Given this list of marker genes TNFSF15, DLL1, AK4, ADAM19, TAB3 (TGF-beta activated kinase 1 (MAP3K7) binding protein 3), EHD1, TGFA, LINC01093, PTGS2, AGPAT4, HCAR3, GK (NCBI Gene Id 2710), UBTD2, MET, KCNJ2, PROCR (protein C receptor), SERPINB7, KBTBD2, LCOR, SLC25A37, ATP6V1E2, SAMD8, HAS1, TBC1D9, ADM, PLGRKT, KANK1, LAMB3 (laminin subunit beta 3), ARHGAP24, TP53BP2 (tumor protein p53 binding protein 2), CTSL, NKX3-1, ITGB8, OSGIN2 (oxidative stress induced growth inhibitor family member 2), RBM17, BCL2A1, SH3BP5, OLIG1, SVIL, SLC11A2, MCEMP1, ACOD1, UPP1, CISH, NFKB1, PDSS1, IL2RA, ADGRE1, ACSL5, ABCA1, CDKN2A, MIR3945HG, CASP5, STEAP4, F3, ZBTB10, CT75, STAT4, MAP3K4, NUP58, SMS, IER5, SAV1 (salvador family WW domain containing protein 1), CPM, AQP9, BATF3, MPZL1, PRR16, MAP3K20, TNF, CCL20, CTSLP8, ZBTB43, CD274, BAALC, DCUN1D3, C11orf96, HRH1, TNFRSF9, RPGR, TRIM36, ST3GAL1, CRACD, CA12, RAB21, GJB2, CXCL2, BASP1, IL10, SERPINB1, SMPDL3A, SLCO4A1, MAP7 (NCBI Gene Id 9053), PIM1, RABGEF1, IL36G (interleukin 36 gamma), OPHN1, SOCS3, YRDC, HEY1, MIR3142HG, PTX3, HS3ST3B1, ELL2, RGS16, STAT3, IL6, AGO2, SLC7A7, SFR1, CLIC4, SGPP2, BATF, NFAT5, CDC42EP3, MTHFS, MFSD2A, ST20, PLAC8, SLC16A10, WTAP, MTF1, CYRIA, SAMTOR, IL1A, CCDC93, MCOLN2, CCL18, MAP3K5, FLT1, USP12, PLAT, IRAK3 (NCBI Gene Id 11213), PFKFB3, SLC1A2, GNG2, SLC2A3, DENND5A, GRAMD1A, AZIN1, ELOVL7, HDAC9, MYO1G, ETS2, SERPINB9P1, RNF144B, BCAT1, OLIG2, SOCS1 (NCBI Gene Id 8651), FPR2, HSPA13, EYA4, NDP, OSM, WFDC21P, ZC3H12A, P2RY2, SOCS2, TRAF3IP2, HES1, ACVR1B, MYO10, TRIP10, IER3, SLC20A1, CCL23, ACSL1, CCL1, G0S2, NFKBIA, TMEFF1, RFTN1, TNFAIP6, MSANTD3, TMEM39A, AKT3, GK3, VNN3P, LIMK2, STK26, FSD1L, DENND3, MIR155HG, IL24, ABHD17C, TNIP3, IL19, FCRL5, TWF1 (twinfilin actin binding protein 1), AFDN, SLAMF1, MRPL52, ENPP4, MAGI2-AS3, GADD45B, here is a description of the gene set: Histone methyltransferases catalyze site-specific deposition of methyl groups, enabling recruitment of transcriptional regulators. In mammals, trimethylation of lysine 4 in histone H3, a modification localized at the transcription start sites of active genes, is catalyzed by six enzymes (SET1a and SET1b, MLL1–MLL4) whose specific functions are largely unknown. By using a genomic approach, we found that in macrophages, MLL4 (also known as Wbp7) was required for the expression of Pigp, an essential component of the GPI-GlcNAc transferase, the enzyme catalyzing the first step of glycosylphosphatidylinositol (GPI) anchor synthesis. Impaired Pigp expression in Wbp7-/- macrophages abolished GPI anchor-dependent loading of proteins on the cell membrane. Consistently, loss of GPI-anchored CD14, the coreceptor for lipopolysaccharide (LPS) and other bacterial molecules, markedly attenuated LPS-triggered intracellular signals and gene expression changes. These data link a histone-modifying enzyme to a biosynthetic pathway and indicate a specialized biological role for Wbp7 in macrophage function and antimicrobial response. Genes up-regulated in bone marrow-derived macrophages with MLL4 knockout: control versus treated with LPS for 2h. Human Gene Set: GSE30971_CTRL_VS_LPS_STIM_MACROPHAGE_WBP7_KO_2H_UP studied in species Homo sapiens from publication Austenaa L, Barozzi I, Chronowska A, Termanini A, Ostuni R, Prosperini E, Stewart AF, Testa G, Natoli G (PMID 22483804)